Given this list of marker genes EDN1, IER3, PELI1, ARL5B, MIR155HG, LAMB3, CXCL2, GJB2, RHOH, TXN, GK, RASGEF1B, SLC9B2, CXCL5, SNX9, NFKB1, GADD45B, YRDC, PTS, TNFSF9, NAF1 (NCBI Gene Id 92345), RYBP, KDM6B, NLRP3, LAMP3, CT75, CD274, GRAMD1A, NOCT, CXCL8, CCR7, MIR3945HG, IL20, BIRC3 (baculoviral IAP repeat containing 3), STAT5A, DLGAP1-AS1, OSM, P2RX4, LDLRAD4, ATP2B1-AS1, MSANTD3, ID2B, DCUN1D3, MFSD2A, GPR84, PLD1, F8, EIF1B, JUN, TNF, LINC00299, C11orf96, DENND4A, TP53BP2, PTP4A1, TIFA, RPGR, MMP7, PLEKHF2, SOD2, NFKBIA, ADM, ERRFI1, SGPP2, HNRNPC, HIVEP2, ACOD1, ANO5, DYRK3, DENND5A, CCRL2, TLCD3A, USP12, KDM7A-DT, NUP58, SFR1, RAPGEF2, IL2RA, PDSS1 (NCBI Gene Id 23590), PSMD5, TAF9, IL6ST-DT, TNIP3, ID2, NFATC1, DNAAF1, DLGAP1-AS2, MAP3K8, IL23A, F3, GPRC5A, PIK3AP1, IL36G, ACSL1, STARD8, CYB5D1, OTUD1 (NCBI Gene Id 220213, OTU deubiquitinase 1), GEM, REL, INHBA, ZC3H12A, SERPINB8, IL15RA, IL1B, STARD4, POLR1F, ADTRP, G0S2, ETS2, NEDD4L, DUSP3, PLK3, TNFAIP3, MAFF, STK26, GADD45A, TNFAIP2, CASP5, HECW2, PLAUR, NFKBID, GCH1, SELENOK, AQP9, NSMAF, LSS, ELOVL7, RND1, PIM2, SAV1, SIAH2, DOT1L, CDK1, CCL4, NMRAL2P, SLAMF7, B3GNT2, ENSG00000284634, PTX3, LINC01465, ZNF674-AS1, NFKBIZ, DUSP1, SLC7A5, IL18, KANK1, TNFAIP6, MAP3K4, CD83, ADORA2A-AS1, TPD52, CFLAR, MIR3142HG, ATP2B1, CSRNP1, DUSP5, SOCS3, FOSL1, UBE2J1, ABL2 (NCBI Gene Id 27), IL10, EGR1, E2F7, SDC4, IL1A, CXCL3, FNIP2, PLEK, PHLDA2, PLA1A (phospholipase A1 member A), PTGS2, DUSP2, PPP1R15B, ICAM1, DDIT4, PIM3, FJX1, ADRB2, CCL18, DRAM1, SFMBT2, STAT4, EREG, AREG, IL12B, DNAJB4, CXCL1, PMAIP1, CCL20, RIPK2, LINC01093, PPP1R15A, BCL2A1, NFE2L2, MGAM, NEMP1, here is a description of the gene set: Genes up-regulated in comparison of monocytes treated with 1 ng/ml LPS (TLR4 agonist) versus untreated monocytes. from publication Dower K, Ellis DK, Saraf K, Jelinsky SA, Lin LL (PMID 18292579) species: Homo sapiens Human Gene Set: GSE9988_LOW_LPS_VS_VEHICLE_TREATED_MONOCYTE_UP TREM-1 is an orphan immunoreceptor expressed on monocytes, macrophages, and neutrophils. TREM-1 associates with and signals via the adapter protein DAP12/TYROBP, which contains an immunoreceptor tyrosine-based activation motif (ITAM). TREM-1 activation by receptor cross-linking is pro-inflammatory, and can amplify cellular responses to Toll-like receptor (TLR) ligands such as bacterial lipopolysaccharide (LPS). To investigate the cellular consequences of TREM-1 activation, we have characterized global gene expression changes in human monocytes in response to TREM-1 cross-linking in comparison to and combined with LPS. Both TREM-1 activation and LPS up-regulate chemokines, cytokines, matrix metalloproteases, and PTGS/COX2, consistent with a core inflammatory response. However, other immunomodulatory factors are selectively induced, including SPP1 and CSF1 (i.e., M-CSF) by TREM-1 activation and IL-23 and CSF3 (i.e., G-CSF) by LPS. Additionally, cross-talk between TREM-1 activation and LPS occurs on multiple levels. While synergy in GM-CSF protein production is reflected in commensurate mRNA abundance, comparable synergy in IL-1b protein production is not. TREM-1 activation also attenuates the induction of some LPS target genes, including those that encode IL-12 cytokine family subunits. Whereas positive TREM-1 outputs are abolished by the PI3K inhibitor wortmannin, this attenuation is largely PI3K-independent. These experiments provide a detailed analysis of the cellular consequences of TREM-1 activation, and highlight some of the complexity in signal integration between ITAM- and TLR-mediated signaling.